Given this list of marker genes Acta1, Myc, Thy1, Actg2, Tmsb4x, Cinp, Cbx1, Ccn2, Sorbs1, Brip1os, Tagln (NCBI Gene Id 21345), Actn4, Dusp6, Errfi1 (NCBI Gene Id 74155), Serpine1, Ptger4, Lats2, Pbx3 (pre B cell leukemia homeobox 3), Ak4, Ccn1, Fhl1, Tnc, Fez2, Igf2, Ly75, Adm, Thbs1, Phldb2, Alcam, Inhba, Irgm1, here is a description of the gene set: from publication Berenjeno IM, Núñez F, Bustelo XR (PMID 17213802) Mouse Gene Set: BERENJENO_TRANSFORMED_BY_RHOA_REVERSIBLY_DN Genes down-regulated in NIH3T3 cells (fibroblasts) transformed by expression of contitutively active (Q63L) form of RHOA off plasmid vector; their expression reverted completely after treatment with Y27632, an inhibitor of ROCK proteins. We have used microarray technology to identify the transcriptional targets of Rho subfamily guanosine 5'-triphosphate (GTP)ases in NIH3T3 cells. This analysis indicated that murine fibroblasts transformed by these proteins show similar transcriptomal profiles. Functional annotation of the regulated genes indicate that Rho subfamily GTPases target a wide spectrum of functions, although loci encoding proteins linked to proliferation and DNA synthesis/transcription are upregulated preferentially. Rho proteins promote four main networks of interacting proteins nucleated around E2F, c-Jun, c-Myc and p53. Of those, E2F, c-Jun and c-Myc are essential for the maintenance of cell transformation. Inhibition of Rock, one of the main Rho GTPase targets, leads to small changes in the transcriptome of Rho-transformed cells. Rock inhibition decreases c-myc gene expression without affecting the E2F and c-Jun pathways. Loss-of-function studies demonstrate that c-Myc is important for the blockage of cell-contact inhibition rather than for promoting the proliferation of Rho-transformed cells. However, c-Myc overexpression does not bypass the inhibition of cell transformation induced by Rock blockage, indicating that c-Myc is essential, but not sufficient, for Rock-dependent transformation. These results reveal the complexity of the genetic program orchestrated by the Rho subfamily and pinpoint protein networks that mediate different aspects of the malignant phenotype of Rho-transformed cells. studied in species Mus musculus